The following is a description of a gene set: studied in species Mus musculus Mouse Gene Set: WP_NUCLEOTIDE_GPCRS Nucleotide GPCRs, and this is the list of marker genes: Tmigd3 (transmembrane and immunoglobulin domain containing 3), Adora1, P2ry4, Adora3, Lpar4, P2ry2, Adora2b, Ltb4r1, Lpar6, P2ry1, Adora2a, P2ry6